Given this list of marker genes Mttp, Scp2, Pltp, Stard4, Apoa1 (NCBI Gene Id 11806), Apoa2, Abcg5, Apoa5, Osbp, Apoa4, Gramd1c, Apoe, Gramd1a, Abcg8, Apob, Npc2, Gramd1b, Stard3, Star, Stard5, Abca1, Osbpl2, Abcg1, Npc1, here is a description of the gene set: Removes a sterol from a membrane or a monolayer lipid particle, transports it through the aqueous phase while protected in a hydrophobic pocket, and brings it to an acceptor membrane or lipid particle. species: Mus musculus Mouse Gene Set: GOMF_STEROL_TRANSFER_ACTIVITY